Given this list of marker genes TYMP, HARS1, BAG3, SAMHD1, MT-ND5, SOX10, PLAAT3, ERCC2, SACS, MANBA, IFIH1, AFG3L2, MT-TL1, MT-ND1, RRM2B, ERCC3, LIG3, ERCC6, NRCAM, MPZ, TREX1, MT-ND6, SPTBN4, RNF168, DNAJC3, RFC1, PMP22, MOGS, POLG (DNA polymerase gamma, catalytic subunit), MT-ATP6 (mitochondrially encoded ATP synthase membrane subunit 6), GDAP1, VRK1, DMXL2, MT-TW, ADAR, RNASEH2B (NCBI Gene Id 79621), RNU7-1, MT-TK, HK1, NEFL, ACO2, ERCC5, RNASEH2C, MT-TV, MT-ND2, PLP1, ERCC4, SH3TC2, POLR3B, LSM11, GJC2, RNASEH1, NDRG1, TFG, COA7, ERCC8, SLC12A6, ABHD12, SELENOI, MT-ND4, RNASEH2A (NCBI Gene Id 10535), PTRH2, ZFYVE26, MT-ND3, DEGS1, here is a description of the gene set: studied in species Homo sapiens Demyelinating peripheral neuropathy Human Gene Set: HP_DEMYELINATING_PERIPHERAL_NEUROPATHY Demyelinating neuropathy is characterized by slow nerve conduction velocities with reduced amplitudes of sensory/motor nerve conduction and prolonged distal latencies.